Given this list of marker genes COL11A1, AGA, RUNX2, MPDU1, SFRP4, SIX2, NOTCH2, ALX1, ATRX, CTSK, TRIM37, ALX3, KCNJ2, FLNA, DNAI1, here is a description of the gene set: Human Gene Set: HP_ABNORMALITY_OF_FRONTAL_SINUS Abnormality of frontal sinus An abnormality of the frontal sinus, one of the mucosa-lined, normally air-filled paranasal sinuses of the bones of the skull. The frontal sinus is located within the frontal bone. studied in species Homo sapiens